The following is a description of a gene set: from publication Chaussabel D, Semnani RT, McDowell MA, Sacks D, Sher A, Nutman TB (PMID 12663451) Genes down-regulated in comparison of macrophages exposed to L. donovani versus macrophages exposed to L. major. Human Gene Set: GSE360_L_DONOVANI_VS_L_MAJOR_MAC_DN Monocyte-derived dendritic cells (DC) and macrophages (MΦ) generated in vitro from the same individual blood donors were exposed to five different pathogens, and gene expression profiles were assessed by microarray analysis. Responses to Mycobacterium tuberculosis and to phylogenetically distinct protozoan (Leishmania major, L. donovani, Toxoplasma gondii) and helminth (Brugia malayi) parasites were examined, each of which produces chronic infections in humans yet vary considerably in the nature of the immune responses they trigger. species: Homo sapiens, and this is the list of marker genes: CASP9, SRPX, OIP5 (NCBI Gene Id 123752), JAK1, DLX4, NCK2, ATP2C1, CHEK1, FSHB, CYC1, ANXA5, DRP2, LITAF, ELF4, DUSP5, GRIA3 (NCBI Gene Id 2892), TIMM8A, ITPKA, LAMB3, ZNF160, CEACAM7, COX5A, CYTH2, MOK, PBX2, MMP15, SH3BP1, FLII, REG1CP, PTPRO, NFKB2, PEX5, PAF1, HLA-DOB, SLC35D2, CXCL3, PRKN, SLAMF1, CELF1 (CUGBP Elav-like family member 1), LIMK2, ZNF230, DMC1, RAB4B, NCALD, DLEC1, PTPN21, EIF3G, ATF6B, RAPGEF2 (NCBI Gene Id 9693), GYG2, PLAUR, RBBP8, AKR1B1, PTPRCAP, TWIST1 (NCBI Gene Id 7967), IL1B, DYRK4 (dual specificity tyrosine phosphorylation regulated kinase 4), CFLAR, CHD1L, FAM131A, MGRN1, UBN1, ZPR1, CDH1, GCH1, CALCA, PYGM, TAF10, CYBA, FBXO46, FSCN2, KRT2, CCDC144A, ACSM1, RELB, OSBPL3, MT3, PPP3CB, STAT4, CD22, ZKSCAN8, DUSP1, PAX9, GFRA1, TAX1BP1, RBMXL2, MYL4, SRP14, ASS1, CSF2, TFDP2, SURF1, PXDC1, CDK17, CCL20, INPP4B, TXNRD1, JAG1, ADRA2C, ZNF44, TNIP1, OPTN, PARD6B, TRIM37, PDPN, HTATIP2, CLIC2 (NCBI Gene Id 1193), SRR, GSTZ1, PRPS1L1, CXCL1, MUC6, HEG1, CIRBP, CNR1, SPAG6, SLC35D1, ABI1, ACTN1, PCDHB17P, PTPRS, GATA6, PRRX1, PDXK, ZNF92, NFKBIA, THY1, IL12B, PADI2, KCNJ3, ID4, MMP10, OVOL3, CYTH1, ADGRE1, KIF3C, PTGES, VWA8, SMURF2, WDR46 (NCBI Gene Id 9277), HPD (4-hydroxyphenylpyruvate dioxygenase), PLA2G7, SERPINI2, GABRB1, RUBCN, CASR, NR1H2, ENPEP, EHD1, HSPA4L, H2BC12 (NCBI Gene Id 85236), PMCH, PLAGL2, DLX2, IQSEC2, CCR7, SOX15, GNRH2, CTRC (NCBI Gene Id 11330), SHC1, PDE4B, MPHOSPH8, AP1G1, MICA, DIO2, CD24, MKLN1, CACTIN, TNFAIP3, MDK, NRG1, TRAF1, PLN, CYRIA, TNFAIP2, SORCS3, ACTA2, H2AC17, PON1, PDE1A, ARR3, SRPX2, SPINK4, GSE1, AMHR2, ACADS, TNFAIP6, CCN1, MARCHF6, TRAPPC6A, BRCA1, CD27, FAM131B, SND1-IT1, MMRN1, RB1CC1, DNAJC3, TNFAIP8, HAGH, KAT5